Given this list of marker genes Chsy1, Sec22b, Adgra3, Nexmif, Crem, Trappc4, Zfp740, Ppp4r2, Hsp90b1, Pip4p1, Cask, Pirt, Arcn1, Scaf11, Dlg1, Igf1, Pax3, Tnpo2, Sp2, Trappc3, Serpinf1, Sri, Ralgapb, Tmem178, Anxa2, Dennd6a, Tnks2, Tbc1d15, Pde7a, Sema6d, Edn1, Atf2, Rabgap1l, Tars2, Folr1, Thbs1, Ktn1, Spred1, Hinfp, Hycc1, Ip6k2, Trim2, Cped1, Ywhab, Bdnf, Tppp, Stc2, Tex11, Kctd10, Cav2, Mmd, Cnn3, Atxn1l (ataxin 1-like), Zfp280d, Syt1, Mfsd14a, Mal2, Matr3, Suz12, Man2b1, Gnpda2, Tbp, Slc8a2, Stmn2, Pik3c2a, Obsl1, Ccsap, Clcn3, Rictor, Ppib, Msantd2, Hmcn1, Slc29a3, Rnf138, Thoc2, Fnip2, Cdk6, Eml3, Utrn, Bcl11a, Hspd1, Nlrp4e, Yipf4, Tpm3, Dach2, Twf1 (twinfilin actin binding protein 1), Nxph2, Sash1, Mapkbp1, Marchf1, 1700066M21Rik, Mctp1, Tpm4, Hmbox1, Cebpz, Ttc7b, Cmpk2, Snai2, Ust, Max, Rit2, Frmd3 (FERM domain containing 3), Prkacb, Zfp236, Raver2, Nup50, Phyhip, Atg13, Lrrc8a, Rnf145, Coro1c, Eif1ax, Setbp1, Tmem243, Tra2b, Thrb, Caap1, Mtx1, Phf6, Ndrg3, Klf4, Adar, Kalrn, Arfip1, Tgfbr3, Dgke, Pax7, Hmgn1, Tspan4, Asxl3, Rrm1, Fam168a, Cfap47, Slc38a3, Wdr48, Slc25a53, Larp4, Hacd3, Ndrg1, Helz2, Zfp800, Spire1, Wars2, Tex2, Vamp2, Rgs19, Hipk3, Cd2ap, D6Wsu163e, Rnf150, Xpo6, Cdc14a, Knop1, Alkal2, Zc3h7b, Mylk, Col25a1 (collagen, type XXV, alpha 1), Eva1a, Bsn, Adpgk, Prlr, Plppr4, Sec63, Adprm, Srgap2, 4930563E22Rik, Plxna4, Cdk14, Arf3 (ADP-ribosylation factor 3), Cbl, Zfp40, Peak1, Cttnbp2nl, Glcci1, Mex3c, Esp34, Myocd, Ccdc166, Bltp3b, E2f5, Lrch1, Ms4a7, G6pdx, Tspyl4, Foxp1, Map1a, Neto1, Ptprg, Kcnip3, Prkce, Kif2a, Slc37a3, Tmcc1, Ss18, Kank4, Ubr5, Creb5, Bach2, Cap1, Sec61a1, Clock, Kmt2e, Fn1, Rfesd, Git1, Tmsb4x, Nfatc3, Pdik1l, Syn3, Josd1, Smim14, Glis2, Frs2, Ube2h, Zfp36l2, Serp1, Ccr1l1, Pla2g4a, Atp6v1a, Wnt3, Azin1, Gpd2, Cited2, Fndc3b, Gja1, Rbm27, Mon2, Phip, Nfatc2, Stard7, Phax, Hnrnpu, Sprn, Tmem18, Unc119b, Smarcb1, Dnajc6, Ywhaz, Stag2, Sox17, Smarcc1, Gkn2, Arap2, Dph6, Wbp1l, Ets1 (E26 avian leukemia oncogene 1, 5' domain), Slc25a22, Ncoa1, Slc25a25, Wnk3, Grk6, Gclc, Nol4l, Arf4, Meox2, Arhgap25, Osbpl7, Snx2, Dach1, Ap1s1, 9230112D13Rik, Glce, Slc39a10, Eeig1, Ube4a (ubiquitination factor E4A), Pdcd10, Nedd9, Miga2, Mecom, Actb, Elf1, Sulf1, Ddx5, Ncl, Entpd7, Mpp7, Ajuba, Ankrd29, Zfp661, Timp3, Hs3st3b1, Fndc3a, Pgrmc1, Stk39, Usp33, Srsf9, Nrp1, Kcnd3, Kat6a, Map4k3, Jade3, Fbxo33, Nxt2, Cndp1, Mmd2, Ank3, Gpr158, Lasp1, here is a description of the gene set: from publication Chen Y, Wang X (PMID 31504780) Mouse Gene Set: MIR_206_3P Genes predicted to be targets of miRBase v22 microRNA mmu_miR_206_3p in miRDB v6.0 with MirTarget v4 prediction scores > 80 (high confidence targets). studied in species Mus musculus